The following is a description of a gene set: Genes containing one or more binding sites for (DBP) in their promoter regions (TSS -1000,+100 bp) as identified by GTRD version 20.06 ChIP-seq harmonization. Human Gene Set: DBP_TARGET_GENES studied in species Homo sapiens from publication Yevshin I, Sharipov R, Kolmykov S, Kondrakhin Y, Kolpakov F (PMID 30445619), and this is the list of marker genes: FUT8, SHC4, SNRPA1, AURKAIP1, STAM, MUC1, CD2BP2, CBLL1-AS1, GPRC5D-AS1, IFT56 (intraflagellar transport 56), INTS1, SON, GABARAP (NCBI Gene Id 201246), ZNF92, TOMM22, SNX15, MED26, POLK, ERC1, NCAPD2, GTF3C4, PRR13, TEFM (transcription elongation factor, mitochondrial), CCNI, PCBP1-AS1, CSPP1, BBS4, BTBD1, ODAD3, SAP30L, SEC61A1, CCNT1, SRSF10, JAK3, MAPKAPK5-AS1 (NCBI Gene Id 51275), COPS7A, DNAAF10, MIR6124, POP5, CKMT2-AS1, C14orf119, ZCCHC8, TARS1-DT, TULP3, SRRT, ANKIB1, RIMOC1, MED24, ILVBL, ETV1, VMAC, SMG5, MYH9-DT, NDUFA5, RPS16, FAM222B, SPHK2, MPHOSPH9 (M-phase phosphoprotein 9), FAM185BP, HMBOX1, ACAA1, DRG2, RER1, RPS6KA1, MSL2, CKS2, CTNNBIP1, WDR27, SH2B1, MBLAC2, IMMT, AFG1L, KMT5A, PARL, ARAP1, ARHGEF28, KCTD16 (potassium channel tetramerization domain containing 16), ILF3-DT, PPP4R3B-DT, SEC16B, RNU6-92P, PPP1R12A, OLMALINC, CNOT10, RNPS1, TXNDC15, ITGA3, POLR1F, TTC33, TEF, TMEM186, SOD1 (NCBI Gene Id 6647), PITPNM1, KCTD10, C6orf89, BCL2L12, VDAC2 (voltage dependent anion channel 2), C15orf61, LRRC37A5P, RXRB, XYLB, NIPBL, CEP97, UBR2, ELL3, DIMT1, SAC3D1 (SAC3 domain containing 1), TXNL4B, NEDD4L, INVS, INTS14, ZNF277, STARD10, MKLN1, MCTS2, ZNF343, TGS1, PIK3C2B, AHCYL2, CHAC1, TUBA1B-AS1, MBNL1, CNST, SENP1, FOXN3, KALRN (kalirin RhoGEF kinase), ACTB, LETMD1, SERTAD1, GSTCD, SETD4-AS1, LAPTM4A, COQ4, SH3BGRL3, MORN1, FOSL1, MMACHC, SEC31A, RPP25, ERAL1, KIF23, SLC20A1, EGR2, VPS50, PCLAF, ENDOV, SPRING1, SLC4A2, SMARCC1, LACC1, CNPY2, SPG7, ANKHD1-EIF4EBP3, ZC3H4, COQ10B, RECQL5, PRKCE-AS1, EIF3B (NCBI Gene Id 8662), S100A2, ZCCHC9, MRPS17, ACP6, PNKD, RAD51AP1, INTS4, VCL, HMGB1 (NCBI Gene Id 3146), METAP2, CCAR2, MIR4482, FBXO38-DT, PLK3, PHB1, ZFYVE1, TBC1D7, TIMM10, WDR55, RN7SL346P, HINFP, RBM34, RFC2, WRAP53, PPOX, SAFB, GANC, COX7C, IQCH-AS1, ANKRD11 (NCBI Gene Id 92821), LCMT1, TIMM50, OGDH, SRD5A1 (steroid 5 alpha-reductase 1), COQ7, FAM83E, EIF2B4, ZKSCAN5, SZRD1, RAB20, CDK5, RNASEK-C17orf49, GNS, VIL1, STAM-DT, RAB5IF, INO80, RPS7, KIF22, NPAT, STK40, COPS5, CCDC28A, CTNND1, RPL12 (NCBI Gene Id 90679), TBC1D23, WDR4, LINC02363, ZCCHC2, HAX1, WSB2, TYSND1, MUS81, SLC30A5 (NCBI Gene Id 79021), BLOC1S2 (NCBI Gene Id 282991), ALG14, CTDP1 (NCBI Gene Id 9150), KLF7, RPL18, CLTA, SLC30A6, NRN1, AP2A1, CBX5, TMEM30A, PIK3R3, HCFC1, PDE6D, EXOSC9, SRSF7, MIRLET7BHG, RGS5, MIR3124 (microRNA 3124), STIM2, MVD, SPINK5, MIR615, PELO, ANAPC10, TOMM22-DT, PPP2R5B, MMP15, RAD9B, PCM1, SMAD5, MRPS30, TATDN1, PSMB5, MAZ, SUPT5H, KRIT1 (KRIT1 ankyrin repeat containing), FEM1A, ATM, ABCE1, SNHG21, TTC27, EGR3, UQCR10, CDK5RAP2, SNHG15, SPATA24 (spermatogenesis associated 24), PPM1G, DOCK4, KLHL7, INTS9 (NCBI Gene Id 55756), FBXO38, BCL2L14, AQR, PANK3, HSPA9, CNBD2, NABP2, TRIM37, SLC25A51, DDX55, TEAD4, EDEM2, USP21, ERP44 (endoplasmic reticulum protein 44), IRF2BP1, FAM81A, ROPN1L-AS1, AHSA1, C18orf21 (NCBI Gene Id 83608), DFFA, EMC7 (ER membrane protein complex subunit 7), RNU6-2, DHX57, MSH5-SAPCD1, METTL18, ETFDH, GBF1, OMA1, PIPOX, TIMELESS, MAPKBP1 (mitogen-activated protein kinase binding protein 1), HUWE1, ING3, LCMT1-AS1, SFXN5, PIP4K2C, ETV5, ENC1, IPPK, THBS3-AS1, THBS1, RPL24, PSMD8, SHOC2, FANCB, ANKHD1, MORF4L1, MIR3677HG, GXYLT1, ZNF219, LUC7L2, STIM2-AS1, PRCC, CNTD1, RAET1K, DGKA, NUP107-DT, HOXC5 (homeobox C5), MYH9, DNAJC25, CYB5A, LINC02889, TSPYL1, DONSON, VMP1, MEA1, DBP, HOXB3, TMEM248, TBCC, CDK17, BAZ2A (bromodomain adjacent to zinc finger domain 2A), RNF6, EXOSC3, EXPH5, EIF5A, IFT20, FTO, DNAAF4-CCPG1, ZNF622, PCNA (NCBI Gene Id 5111), KDM2A, SH3BP5L, KIF23-AS1, C6orf52, PPFIA3, RNF207-AS1, NANP, RPL5, RPL37 (ribosomal protein L37), CHRNB1, JUP, LAMP1, SIL1, NMRAL1, RNF213-AS1, ZNFX1, TOLLIP, CCNL2, ZSWIM4, TNFAIP8, ALKBH7, MTFR1, DMXL1, TAF1A, CNOT8, TMEM79, CHCHD6, CAB39L, SEM1, SLC20A1-DT, NCOA7, PURB, CRADD, HCFC1R1, RAB19 (RAB19, member RAS oncogene family), VPS11-DT, KATNB1, HMOX2, LAPTM4A-DT, NDRG1, DDX39B, OST4, ENSG00000266088 (NCBI Gene Id 105371773), SREK1, PLEKHA8, FAR2, ZFYVE26, ZSCAN22, PPP1R11, RPP14, HIPK1, FAM133B, HSPA13, ZBED5, CD164, FDXACB1, RNF186-AS1, SP140L, GPBP1, IRF3, LMAN2, RGS2, ZNF35 (zinc finger protein 35), HNRNPUL1, MXD3, CDIPTOSP, DNAAF4, WDR75, SEC11A, TMEM198, CAP1, MKKS, TMEM242-DT, EPS15-AS1, NR4A2, MIR4515, ZNF398, BUB1B, RABGEF1, SOD1-DT, SLC30A6-DT, CDK19, RFX2, NDUFA11, HIGD2A (HIG1 hypoxia inducible domain family member 2A), OSBPL3, RPL14, EIF5, ZNF408, PPIL2, GCA, PA2G4, ZFP36, TYW5, CITED2, DCAF6, GPR19, AIRIM, NDUFA9, EGR1, SLTM, SPSB3, STAT2, ITGA1, SFN, SNORD95, MRPL46, HJURP, MRPL47, ALDOA, MED13, DNAJC25-GNG10, GBP2, CDKN1A, PLEKHJ1, CASC11, CFAP298-TCP10L, NMNAT1, FBXL18, SLC9A3-OT1, THOC6, TFB2M, HACD2, SMTN, CDC37L1-DT, WASHC4, VTRNA1-2, TMEM184A, SMPD3, LYRM2, ENSG00000268129, SETDB2, MAP3K5, COQ7-DT, MAP3K14, PRDM10, DPH3, PPIG, LEF1-AS1, GPX4, MRPL20, PICART1, SAP30L-AS1, PRPF19, NAT10, H2AC7, HIGD2B, RPS13, TMEM87A, HIPK1-AS1, VPS41, ZNF391, CYB561D1, INO80B, VPS28, RANBP10, C1orf159 (chromosome 1 open reading frame 159), GOLGA4, MIR3912, HSD11B1L, SUPV3L1, FBXO4, LINC00649, ZMAT2, RARS1, CBLL1, CDKN2D, MIR7845, LSM5, RHNO1, PCBD2, NDUFC1, LY75-CD302, ZNF444, H2AZ2-DT, NIP7, SRSF1, METTL26, TTLL13, SNORD59A, HDGF, CRTC3-AS1, ZNF394, SYNJ2, ZWILCH, SRSF5, CHMP1B, THAP9-AS1, MRPL4, GTF2IRD1P1, PLXDC1, NDUFB5, RPS26, TMEM242, CPD, EIF2A, ATP6V0E1, SLC25A44, TARS1, SART3, HS3ST1, ZNF181, MAP3K11, CCNB1IP1, HYCC1, ZBTB8OS, C1GALT1, CCDC157 (NCBI Gene Id 550631), CCDC28A-AS1, TIMM22, CALR3, STX16-NPEPL1, LEMD2, EXOSC10, DNAJB11, VRK3, AKAP8L, RPL6, SUGCT, DAB1, MICOS13, NDUFAF4P1, ALDH3A1, MOSPD2, GLIPR2, PEMT (phosphatidylethanolamine N-methyltransferase, NCBI Gene Id 10400), SF3A2, TTC14, NKAPD1, CHD2, TNPO3, HEMK1 (NCBI Gene Id 51409), CXXC1, ARFIP1, FIRRM, JOSD2, ZFAND6, U2SURP, ZNF815P, TBCCD1, NCK1-DT, TMEM59, TMEM30A-DT, FRYL, ZCCHC4, LIN52 (NCBI Gene Id 91750), TMEM259, PRR14L, NELFA, NAA60, TUFT1, SLC39A9 (NCBI Gene Id 55334), COX16, ANAPC7, PRMT3, TP53TG1, UBE2D3-AS1, NCBP1, CFDP1, PRKCSH, SART1, VIRMA, GEMIN6, GSPT1, YJU2, TARS2, RAB11B, DAXX, TPGS1, YARS2, GRK6 (G protein-coupled receptor kinase 6), ENSG00000232995, SLC9A3-AS1, PRPSAP1, PHF12, MCRIP2, LRP6, MRPL18, PSMA3, SNRPD3, MYPOP, SERP1, ZSCAN21 (zinc finger and SCAN domain containing 21), DHX35-DT, DNAJC14, PYM1 (NCBI Gene Id 84305), KBTBD6-DT, GALK2, DRAIC, CHPF, ACTMAP, SPTLC2, VPS11, TTI1, H2BC26, FASTKD2, EEF1G, NME1, TCP1, ABHD13, NBPF1, NEMF, MRPS11, RNF207, TMC4, LINC02441, UBE2M, GMPPA, HSCB, RIC8B, HNRNPA1, C2orf15 (NCBI Gene Id 150590), EMC4, MBOAT7, SCARNA16, TTC17, SGK1, AGPAT4, HTD2, PFKFB3, ARPC4 (actin related protein 2/3 complex subunit 4), CEP120, SH2D6, MINDY2-DT, CHEK1, ATP5F1B, BCL2L1, TMEM106C, CHORDC1 (cysteine and histidine rich domain containing 1), ARL15, ZNF337-AS1, FDFT1, AGO3, MAIP1 (matrix AAA peptidase interacting protein 1), LRSAM1, CBX3, HEXIM2, CCDC124, RWDD1, SLC38A10, ABCF2, DDX39B-AS1, ENTPD1-AS1, RPL32P3, BTD, UBL7, SAE1, HEXIM2-AS1, OTUD6B, SAP30BP, TMEM116, HPS5, PTPRB, C6orf62, CLPB, ZNF764, PSMC5, H2AC17, MATR3, SEMA3C, NOP16, SNORD12C, TMCC3, PDCL3, HOXB6, COA1, RPL36, PNPLA8, PTGR2, XRN2, SF3A3, DET1, SF1-DT, CAND1, TPD52L2, ZBTB3, RCHY1, NDUFS2, PPP1R12C, HGH1, SNRPA1-DT, DYNC2I1, TRAPPC6B, ANAPC5, CCDC91, DOHH, ECH1, NFE2L2, KLHL28, PLBD1-AS1, PPIL3, EGR4, TSNAXIP1, ECSIT, SRF, TRIP4 (thyroid hormone receptor interactor 4), PPP4R3B, CD2BP2-DT, CCDC138, FAM220A, LARS1, PPP2R3C, MYO1E, THAP4, DPP9, CHTOP, WDR5B, PYGB, CLIC1, RPGRIP1L, CAMTA2, TSPAN8, KNTC1, SPEF2, BICD2, SNHG20, PLAGL2, THAP9 (NCBI Gene Id 79725), PFDN1, ZSWIM6, TNFAIP1, GPR108, CDIN1, HNRNPL, HIBCH, LIG4, MBNL1-AS1 (NCBI Gene Id 401093), ALDH6A1, HILPDA-AS1, ZFAS1, BCAT2, ZNF3, TUBA1B, PSMB6, GSKIP, DCTN4, PSPH, SCAF11, CTU1, ENSG00000246308, SERBP1, PPP6C, CEP85, OTUD6B-AS1, TAF1A-AS1, METTL3 (methyltransferase 3, N6-adenosine-methyltransferase complex catalytic subunit), TRIP10, C1orf174, MIR4999, GTF2H1, TAPBPL, RNF44, CYREN, TM2D3, LINC02777, ELL, LMCD1, TMEM101, EXT2, IK, RPL13A, MAD1L1, RNF20, ZBTB40, CREBL2, DSE, GPR107, RCBTB2, INTS2, RPL7L1P8 (NCBI Gene Id 402152), HDAC4-AS1, PKP2, DDX12P, MBD1, USPL1, TPM1, AIDA, NPM3, BANP, PNO1, AKAP3, CLN6 (CLN6 transmembrane ER protein), AURKA, LINC00511, SPAST, AP4B1, MIDEAS, TOX4, TMEM147 (NCBI Gene Id 84721), STAT6, PGBD4, ITFG2-AS1, POLR3G, NIPSNAP2, PIH1D2, TSN, CATSPERD, FRAT2 (FRAT regulator of WNT signaling pathway 2), MARCOL, BCAS2, IFT70A, FAM117A (family with sequence similarity 117 member A), RRM1, PPRC1, PSIP1, LONP1, MPC2, CFAP68, COG8, KLHDC3, RNF139-DT, ZNF688, RAB6A, CEP290, FOXD1, ARHGAP1, CRK, FOS, RPS14, ARSK, CLPTM1, BRD9, PRKRIP1, DCP1A, TSGA10, RAPGEF6, GOT1-DT, BLM, PRORP, CELF1, EPHB4, SAMD4B, STRIP1, ATIC, RAD9A, DOLK, MPDU1-AS1, RACGAP1, POLR3F (NCBI Gene Id 115527), RPL7L1, SF1, ACBD6, RN7SL521P, USP8, DIABLO, SF3B5, POLR2A, UQCC2, H2BC7 (NCBI Gene Id 8343), CCNB2, TMTC3, SETD4, CDC42EP4, CCDC192, NLRX1, POC1B-GALNT4, TMX2, TBC1D31, USP31, COX8A, ZNF146, CNNM2 (NCBI Gene Id 54805), ZNF689, INTS5 (NCBI Gene Id 80789), UBE4A, PSD, UBE3A, ETV6, FAM168A, RNU4-1, MRPL20-AS1, EEF1E1, ZNF425 (NCBI Gene Id 347684), RAB11B-AS1, AFG3L1P, MPDU1, TRMT10C (NCBI Gene Id 54931), MORN2, VIPAS39, PICK1, DIAPH1, PPP1R37, MSH5, NUBP2, MRPL32 (mitochondrial ribosomal protein L32), MDH1B, SARS2, ADPGK-AS1, AHI1-DT, UBLCP1, CNN2, INTS13, ZNF12, SPAG7, PTPA, MGRN1, TMEM161B-DT, NUMBL, GGCT, RPL27, RPL22, FAR1, SNORD49B, RSL24D1, DHX38, KDM3A, EIF3H, HILPDA, PRC1, NECAP2 (NECAP endocytosis associated 2), IPO8, SLC7A6 (solute carrier family 7 member 6), BTN3A2, ABCF1, C6orf120, RPS27A, EXOSC10-AS1, MRPS12, TTBK2, ARF6, COA3, ATG4C, ITFG2, MPLKIP, ADAP2 (ArfGAP with dual PH domains 2), CHCHD3 (NCBI Gene Id 54927), ATF3 (activating transcription factor 3), SF3A1, GPD1L, TLE3, BTRC, RNU7-27P, NDUFAF3, NDUFB2-AS1, MNS1, CALU, INTS12, NSMCE3, CDC42SE1, DIAPH1-AS1, STEAP1, SWSAP1, RBM28 (NCBI Gene Id 55131), TAF7, FAR1-IT1, FUZ, THOC1-DT, SDR39U1, NUP205, NUCB1, ZNF143-AS1, PEAK1, BBIP1, ZNF565, BBLN, GABPB2, IVNS1ABP, NUP107, ADO, FBXO45, POR, RBBP4, EMSY-DT, DUSP6, HOXA10-AS, KRT8, PEDS1, MRPL51 (mitochondrial ribosomal protein L51), LCA5L, FTSJ3, BROX, ZBTB11, BBC3, RNF167, BICRAL, PIK3R1, CPEB4, HACL1, EPB41L4A-AS1, PLAC8, CNOT4, NUMA1, ABHD5, TMEM161B, C12orf43, RAB11A, ADK, RBM25 (NCBI Gene Id 58517), AHCTF1, KIF2C, GRPEL1, CEP57, ROPN1L, VIRMA-DT, MCRS1, PPP4R3A, ALKBH2, TACC2, SET, DYNC2I2, DCLRE1B, CD27-AS1, MYLK-AS1, CALM2, CCT6A, DIPK2A (NCBI Gene Id 205428), SNHG29, FIS1, ZMAT5, ZNF672, CIPC, SNORD84, USP36, ZNF473, ESYT2 (NCBI Gene Id 57488), OXNAD1, TMEM147-AS1, RAD52, DDX31, PRKCE, POLG2, NR6A1, TIAL1, UBE2H, DALRD3, YIPF5, NDUFS1, EIF2B5, NDUFV3, PRDM1, SCAMP5, DEDD, CDK4, UBAP1, SUPT4H1, H3C12, MAPKAPK5, FMNL3, CCDC163, MYL5, ASNS, OCEL1, SHF, THADA, RACK1, EEF1E1-BLOC1S5, KHDC4, AARSD1, ARF4, NDUFB3, ADPGK, NPM1, SCAF1 (NCBI Gene Id 58506), ZC3H10, WDR5B-DT, AHCY, NDUFAF1, LIMA1, AMN1, PARPBP, RSPH3, PRPF19-DT, NUF2, RSBN1L, MED25, TICRR, NUP37, HMG20A, NUP188, RNA5SP146, NIF3L1, SETD6, THA1P, CDIPT, LRRC51, OIP5, POU2F1, TSEN34, UFD1, SETD1A, CDC45, WDPCP, CDS2, INPP1, PPWD1, GOT1, EIF3F, SNRPA, MKLN1-AS, TSPAN17, TSTD2, C10orf95-AS1, HOMER1, ST3GAL3, EXOC7, FBXW7, FERRY3, DROSHA, PRPF40B, SNX17, TBX3, TMEM187, SNRPB2, TADA3, LTO1, GOLM2, TMEM198B, THAP6, TNFRSF1A, LZTR1, SECISBP2L, SNX8, TRIM36, NME1-NME2, MINDY2, AP1M1, DIP2C-AS1, TPI1P2, H2AC6, ATP10B, POC1B, RNF34, SLC28A2-AS1, NDC1, NUSAP1, TM4SF5, UBE2D3, PEDS1-UBE2V1, ADAM10, GCC1, CAPG, CFL1, ZNF614, MRPL42, PARP6, SLC22A4, AHNAK, NAA15, GRAMD2B, KAT7, INO80B-WBP1, DERL1, OTUD7A, MRPS33, SLC25A40, ARK2N, IFNAR1, EEPD1, RABAC1, STIP1, GSTO2, SLC25A48, ZNF184, ZDHHC5, MCMBP, NOP53, CCDC146, EIF3D, CSTF2T, TRNAU1AP, ATF7IP, TTC1, MATCAP2, SLC25A53, BOD1, WDR12, ZC3H15, NBEAL1, C19orf53, C19orf44, FBXL15, TRMT11, ESYT1, GPN3, SEC23A-AS1, PCGF1, S100PBP, NDUFB2, SKIC3, RNASEK, METTL2B, SRCAP, STXBP4, TCF7, HYCC2, POU2AF1, UBN2, MRPS30-DT, ANO10, MYG1, MAP3K7, CACTIN, MPV17, SCAMP3, COPS7B, SNHG16, TM9SF2, BDP1, C4orf46, PCNX3, KBTBD6, RPRD2, SFSWAP, SNAI3-AS1, IL5 (interleukin 5), C9orf72, CFAP298, TIGD4, STX16, FARSA, GOLGA1, SLC12A9, NDUFA2 (NCBI Gene Id 4695), SLC36A1, FBXO16, SMU1, NDUFS5, DPP8, FAM76B, GUSB, LINC01765, DHPS, RNF139, H2AZ2, TOLLIP-DT, RUFY1, UNC13D, GUCD1, LZTFL1 (NCBI Gene Id 54585), WDR53, APTR, SNORA13, RPSAP31, ENSG00000232732, KRCC1, PLEKHG2, ZNF484, KCTD7, PRDM10-DT, FGFR1OP2, VDAC3, UBR1, TNPO1, GALNT8, VCPIP1, SDE2, RNU5E-1, ACTR1A, KLHL7-DT, ARL6IP1, SLC25A11, SH3BGR, LZIC, FOXL1, SPTLC3, ARPC4-TTLL3, TRIB1, SLC24A1, LINC00265, ATF4, PGAP4, PLBD1, LINC01635, EIF4G2, MFSD4A, ARL4A, RAD51AP2, MORN4, ENSG00000257184, RNFT2, SLC35B1, GPR137 (NCBI Gene Id 56834), RAD50, HSPA4, ACTG1, FOSB, IPO11, MED19, UBE3B, WDR36 (NCBI Gene Id 574015), POLI, AKT1S1, COPS2, RBM22, SEC23IP, MRPL34, AHI1, TRIP13, KDSR, H2BC17, STK25, HNRNPA2B1, ZFP36L2, TTC32-DT, TCEANC2, CERT1, EMSY, TMEM179B, SLC12A6, LSM7, TMPO, GTPBP10, AAAS, SLC38A4-AS1, ANKRD13A, RBSN, UBE2H-DT, VPS29, CROT, CCDC174, TRMT13, CENPK, FBXO46 (F-box protein 46), DNAJB1, RPRD1B, ZNF410, BAZ1B, ANAPC15, FBXO24 (NCBI Gene Id 94779), RBBP5, GSTK1, ATG16L1, CAPN8, SLX4IP, CSTF1, MEGF8, LINC01852, GMCL1 (NCBI Gene Id 64395), HDAC4, TBC1D17, POP4, LY75, GART, SEC14L1, CALCOCO1, LMCD1-AS1, RPS6KB2 (ribosomal protein S6 kinase B2), TTC14-DT (NCBI Gene Id 101928856), P4HB, FGD4, USF1, LRCH4, LINC02168, BET1, HM13, TMEM39A, PFKM, SLC39A7, ZFP37, NSUN2, TOMM40L, PTGES3, NUP155, CHEK2, RSU1, PARP4, NOP2, ERP29, EIF4ENIF1 (NCBI Gene Id 56478), UBC, PELO-AS1, SASS6, AKTIP, ERH, PMM2, ATG4B, SYMPK, NDRG3, VPS37B, MCL1, L3MBTL2, PLK2, SLMAP, TRUB2, VAMP4, BMERB1, AP3B1, ATP5ME, MDH1, TMBIM6, THOC1, CDK12, TCP11L1, BICDL3P, LTN1, AAMP, PHKB, SAFB2, SP1 (NCBI Gene Id 6667), SMG9 (SMG9 nonsense mediated mRNA decay factor), MVB12A, PAK1IP1, PSMD3, GNL1, SERF2, AP1S1, NGRN, C5orf22, RPS27, MAN1B1, SIAH2, DUSP5, UPP1, EEF1B2, TOGARAM1, IFRD1, DZANK1, TNRC18, SNRNP200, ING4, UBL7-DT, NIPA2, MIR4453HG, CLP1, CSE1L-DT, ILF3, CLN3, CENPBD1P, RAB2B, ZNF143